Given this list of marker genes Mme, Sod1, Fosl2, Mir449b, Plekha1, Clic4, Atrx, Zfp950, Spr, Sik3, Hmga1, Foxs1, Akp3, Ercc1, Pls1, Rara, Apba2, G6pdx, Nfix, Meg3 (NCBI Gene Id 97845), Htra2 (HtrA serine peptidase 2), Alms1, Gpat4, Ncoa3 (NCBI Gene Id 99361), Haglr, Mtor, Coa5, Mir34b, Fto, Abl2 (ABL proto-oncogene 2, non-receptor tyrosine kinase), Igf2, Llgl2, Gdf15, Ikzf1, H19, Tal2 (NCBI Gene Id 21350), Ercc5, Pex5, Cela1, Bbs4, Col3a1, Smo, Etnk2, Dlk1, Garem1, Cntnap2, Brca2, Aaas (achalasia, adrenocortical insufficiency, alacrimia), Slc1a2, Ezr, Mfsd8, Tnks2 (tankyrase, TRF1-interacting ankyrin-related ADP-ribose polymerase 2), Bloc1s6, Gamt, Fxn, Stat3, Icmt, Plag1, Notch2, Six3, Dmd, Fkbp8, Ankrd26, Adrb2, Rc3h2, Slc6a3, Unc79, Zfp36l1, Plac8, Hoxa5, Wdr11, Atrn, Klf2, Pde4d, Ncor1, Zfp640, Prickle1, Pcnt, Rarg, Smpd3, H3f3b, Comp, Stat5b, Galnt3, Hmga2, Ercc2, Mir34c, Apba1, Pkdcc, Norad, Lgmn, Vil1, Nipbl, Prlh, Creb1, Rbbp6, En1, Mbd5, Drd2, Drd3, Stc2, Sgip1, Chd7 (NCBI Gene Id 57137), Stk40 (serine/threonine kinase 40), Adarb1, Comt, Socs2, Otoa, Atf5 (activating transcription factor 5), Sh3pxd2b, Atp8a2, Selenom, Dnaaf3, Slc12a5, H3f3a, Heg1, Kat2a, Ghsr, Ihh, Kdm2a, Palb2, H2-Q2, Vps13a, G6pc1, Sgpl1, Ccm2, Atp1a3, Gdf5, Sco1, Zfx, Gpr21, Pou3f2, Rai1, Fendrr, Rpl29, Rasal2, Hesx1, Ep300, Siah1a, Hsf1, Cacna2d2, Add1, Kdm6a, Ttc8, Agt, Gh, Ankrd11, Adrb1, Ptch1, Sptbn4 (NCBI Gene Id 80297), Odad3, Cox10, Rmi1, Taf10, Trp53, Gnasas1, Large1, Ift80, Xrcc2, Tns2, Plec, Pmp22, Zmpste24, Gpx4, Ercc6, Brinp3, Pcdh15, Igf1, Adrb3, Ctc1, Kmt2c, Atxn2, Mfsd2a, Pou1f1, Ptpn11, Mkks, Slc12a2, Duox2, Dio3, Sos1, Dlg1, Sptbn2, Mir449a, Pantr2, Scnn1b, Pik3ca, Stil, Chaserr, Mir449c, Ndufs6, Hhex, Wwtr1, Cdkn1c (NCBI Gene Id 12577), Ghr, Slc25a25, Nek1, Bcl2, Abcc1, Gins3, Tcf7l2, Ext1, Bbs2, Wdtc1, Afg3l2, Rarb (NCBI Gene Id 218772), Dhcr7, Tshr, Gpam, Slitrk1, Ghrh, Wdr48, Atm, Dicer1, Enpp1, Stat5a, Helt, Guca2b, Atn1, Arid5b, Ppib, Nppc, Ar, Flt3, Tarbp2, Brinp2 (bone morphogenic protein/retinoic acid inducible neural-specific 2), Tbl1xr1, Npy1r, Tmed2, Lncpint, Xpa, Npr2, Csf1, Flvcr1, Mir205hg, Gpd2, Ppp1r13l, Grhl2, Daxx, Slitrk6, Hdac3, Sp2, Azgp1, Slc4a10, Suv39h1, Gmnc (NCBI Gene Id 385639), Gigyf2, Gnas, Slco1a6 (solute carrier organic anion transporter family, member 1a6), Ghrhr, App, Vps13b, Celf1, here is a description of the gene set: The increase in size or mass of an entire multicellular organism, as opposed to cell growth. Mouse Gene Set: GOBP_MULTICELLULAR_ORGANISM_GROWTH species: Mus musculus